Given this list of marker genes RSPO2, COL1A1, MSTN, TPST2, CENPL, DPH6, ACOT2, MKNK1, AKTIP, ABCC5, PHF24, FCRLA, SEPTIN6, ASTN1, ARK2C, CLIP3, TBX6, RGMA, KAAG1, PAK3, PLEKHG3, PNKD, PDCD1LG2, MASP1, PCDH17, RGS20, SYPL2, NLRP4, CELSR2, PAX9, SNRNP27, BCAM, EP300, ALKAL2, SAMD4B, IPO9, SYP, BMF, FMR1NB, PDE7A, CIDEB, FKTN, GAGE1, ICAM5, C17orf78, SUMO1, LYPD6B, RASAL2, S100A10, CPSF4, ARHGEF2, SHANK1, RBFA, ENPP1, FUBP3, USP15 (NCBI Gene Id 9958), PPIB, JTB, TRAPPC8, NTRK2, DISC1, EIF5A (eukaryotic translation initiation factor 5A), SON, RAP1A, CASP2, STIM1, HSPA1L, TAF5L, ASCC2, AHNAK, KIF20B, CCDC85A, here is a description of the gene set: from publication Chen Y, Wang X (PMID 31504780) species: Homo sapiens Human Gene Set: MIR6734_5P Genes predicted to be targets of miRBase v22 microRNA hsa-miR-6734-5p in miRDB v6.0 with MirTarget v4 prediction scores > 80 (high confidence targets).